Given this list of marker genes Fgf17, Fgf7, Fgf10, Fgf18, Fgf8, here is a description of the gene set: Mouse Gene Set: GOMF_TYPE_2_FIBROBLAST_GROWTH_FACTOR_RECEPTOR_BINDING Binding to a type 2 fibroblast growth factor receptor (FGFR2). studied in species Mus musculus